The following is a description of a gene set: Mouse Gene Set: GOBP_MESENCHYMAL_CELL_DIFFERENTIATION studied in species Mus musculus The process in which a relatively unspecialized cell acquires specialized features of a mesenchymal cell. A mesenchymal cell is a loosely associated cell that is part of the connective tissue in an organism. Mesenchymal cells give rise to more mature connective tissue cell types., and this is the list of marker genes: Ovol2, Sp6, Zeb2, Coro1c, Clasp1, Jag1, Sema4g, Ednra, Sema6c, Bmp4, Eomes, Ednrb, Spred3 (NCBI Gene Id 101809), Sema4f, Dsg2, Smad4, Adipor1, Hmga2 (high mobility group AT-hook 2), Plaur, Tbx3, Msx1, Alx1, Sox9, Ppp3r1, Kat8, Cyp26a1, Akna, Pax2, Sdhaf2, Slc39a10, Nfatc1, Gata5, Sdcbp, Wnt16, Spry1, Sema5b, Msx2, Six2, Rflnb, Ldlrad4, Isl1, Vegfa, Fbxo11, Mef2c, Tcof1, Hnrnpab, Ext1, Otud5, Dab2, Epb41l5, Nog, Epha3, Dicer1, Mark1, Flna, Adam8, Phldb2, Dag1, Smad2, Phactr4, Bmpr1a, Ranbp3l, Tbx1, Glipr2 (NCBI Gene Id 97132), Smo, Cdc42, Zic5, Sema3g, Cited2, Timp3, Wnt10a, Phox2b, Tgfb1, Tmem100, Bcl2, Tgfb1i1, Nrp2, Trim62, Hif1a, Arb2a, Tcf7l2, Sema3b, Stat1, Pitx2, Bcl9l (B cell CLL/lymphoma 9-like), Tapt1, Sema4d, Grem1, Hes1, Erbb4, Dact3, Fn1, Osr1, Cfl1, Notch1, Edn3, Loxl3, Axin2, Foxa2, Ager, Sema6a, Twist1, Fgfr2, Pdcd4, Mad2l2, Ddx5, Crb2, Smad3, Sema5a, Rdh10, Slc39a6, Chrd, Hey1 (hairy/enhancer-of-split related with YRPW motif 1), Tgfbr3, Sema4c, Mir452, Gsk3b, Tbx20, Snai2, Ppp2ca, Rps7, Nolc1, Spred2, Cyp26c1, Foxc2, Snai1, Gdnf, Spred1, Foxa1, Six1, Tsc2, Usf3, Sema7a, Foxc1, Eng (endoglin), Sema3e (NCBI Gene Id 330043), Rian, Tgfbr2, Il6, Sema6d, Gata3, Wnt5a, Ctnnb1, Phldb1, Fam83d, Il1b, Mdk, Smad7, Rock1, Efnb1, Pdcd6 (NCBI Gene Id 18570), Wnt4 (NCBI Gene Id 22417), Agt, Spry2, Wnt2, Col1a1, Cdh2, Tcf21, Tasor, Gsc, Dab2ip, Ret, Pawr, Kbtbd8, Tfap2a, Myocd, Nrtn, Aldh1a2, Pofut2, Acvrl1, Notch4, Rock2, Sema3d, Kitl, Gja1, Pax3, Mapk1, Htr2b, Acvr1, Sox8, Pax6, Sfrp1 (NCBI Gene Id 72362), Heyl, Pef1, Fermt2, Spsb3, Mapk3, Dlg5, Sox10, Olfm1, Trip10, Hpn, Efna1, Loxl2 (lysyl oxidase-like 2), Zfp703, Fbxl17 (F-box and leucine-rich repeat protein 17), Frzb, Pdpn, Mtor, Nrp1, Qki, Folr1, Rtn4, Zfp750, Edn1, Hey2, Bambi, Sfrp2, Fuz, Tgfbr3l, Pten (NCBI Gene Id 70161), Rbpj, Ankrd11, Lef1, Ddx17, Aplf, Ptk2, Bmp2, Epha4, Amer1, Fgf8, Nkx2-1, Ell3, Sema3f (sema domain, immunoglobulin domain (Ig), short basic domain, secreted, (semaphorin) 3F), Gbx2, Polr1b, Lama5, Bmp7, Il17rd, Lrg1, Emp2, Klhl12, Shh, Fgf10, Ncam1, Kdm1a, Sema3c, Tgfb2, Radil, Cul7, Fgf15, Sema4b, Hand2, Ezh2, Sema4a, Sema3a, Wnt11, Hdac2, Mcrip1, Tiam1, Adam15, Vasn, Gcnt2 (glucosaminyl (N-acetyl) transferase 2 (I blood group)), Fgfr1 (fibroblast growth factor receptor 1), Zfp64, Lrp6, Clasp2, Sema6b, Vangl2, Wwtr1, Tgfb3, Zic2, Tgfbr1, Trim28, Has2, Rgcc